The following is a description of a gene set: Any process that modulates the rate, frequency, or extent of cartilage development, the process whose specific outcome is the progression of the cartilage over time, from its formation to the mature structure. Cartilage is a connective tissue dominated by extracellular matrix containing collagen type II and large amounts of proteoglycan, particularly chondroitin sulfate. species: Mus musculus Mouse Gene Set: GOBP_REGULATION_OF_CARTILAGE_DEVELOPMENT, and this is the list of marker genes: Wnt5a, Bmpr1b, Hoxd11 (NCBI Gene Id 319663), Rflnb, Smad3, Rara, Smpd3, Prkg2, Ihh, Shox2, Kat2a, Thrb, Glg1 (golgi apparatus protein 1), Bmp1, Lnpk, Maf, Ccn4, Bmp10, Chadl, Snai2, Wnt9a, Idua, Mustn1, Pth, Bmp4, Gdf5, Mdk, Ccn1, Sox6, Nkx3-2, Runx2, Bmp2, Adamts12, Pkdcc, Rarb, Zbtb16, Grem1, Frzb, Lep (leptin), Smad7, Pthlh, Fgf18, Gdf2, Ptpn11, Nr5a2, Tgfbr1 (NCBI Gene Id 674605), Six2, Scx, Ltbp3, Smad1, Trps1, Sox9, Nog, Scin, Axin2, Rflna, Rarg, Bmp6, Ccn2, Gdf6, Loxl2, Mkx, Adamts7, Por, Gli3, Gli2, Sox5, Ctnnb1, Ctsk, Tapt1, Zfp219, Tgfb2, Mboat2, Hoxa11, Efemp1, Bmpr2, Tgfb1 (transforming growth factor, beta 1), Rela